Given this list of marker genes ZNF385A, PRR36, SCRT1, KLK9, VSTM2L, FGD5, EEF1A2, AAK1, ATP1A3, TLX3, SOBP, TGFB1, GRB10, NFIX, OTP, PAX2, SLC29A3, DLGAP3, TRIM48, here is a description of the gene set: Genes predicted to be targets of miRBase v22 microRNA hsa-miR-3196 in miRDB v6.0 with MirTarget v4 prediction scores > 80 (high confidence targets). from publication Chen Y, Wang X (PMID 31504780) Human Gene Set: MIR3196 species: Homo sapiens